Given this list of marker genes Sde2, Lsm6, Rbm48, Skic3, Ctnnbl1, Angel2, Papolb, Ttf2, Prmt9, Rbm15, Sart1, Tsen54, Prmt5, Gemin6-ps, Rbm42, Taf7, Snrpc, Ncbp3, Prpf40a, Cnot3, Gtpbp2, Cpsf2, Tut4 (NCBI Gene Id 320841), Mex3d, Zrsr2, Hnrnpk, Nudt16 (NCBI Gene Id 75686), Dhx15, Mettl14, Cwc22rt3, Cdc5lrt7, Prkrip1, Apobec1, Lsm1, Snrpb2, Cwc22rt6 (NCBI Gene Id 668119), Alyref, Dnajc17 (NCBI Gene Id 97566), Magoh, Ecd, Zmat5, Arb2a, Zbtb7a, Tent5c, App, Gemin5, Tsen2 (NCBI Gene Id 381802), Gm7324 (NCBI Gene Id 652988), Ssb, Xab2, Luc7l3, Tent5a, Obi1, Scaf8, Mtrex (Mtr4 exosome RNA helicase), Hipk3 (NCBI Gene Id 15259), Rbm7, Ess2, Dnajb11, Pcid2, Pparg, Scnm1, Taf5, Ahcyl1, Mtor, Tirap, Sart3, Samd4, Dazl, Lgals3, Cnot6, Pelo, Hnrnpr, Ago2, Igf2bp1, Hnrnpa1, Rbm14, Nr1h3, Nanos1, Tfip11, Rbmy, Ddx39a (DEAD box helicase 39a), Prpf18, Cmtr2, Zfp36, Iws1 (NCBI Gene Id 73473), Senp1, Ctif, Scaf11, Snrnp40, Ddx5, Fmr1, Prpf39, Khdrbs2, Rnpc3, Safb2, Mir7578, Eif4a3l1, Ppil1, Pus7l, Cd2bp2, Larp7-ps, Cwf19l2, Zc3h3, Wdr33, Hmx2, Nova1, Pnrc2, Raly, Gas5, Rbpms2, Dhx9, Ppp1r8, Puf60, Upf1, Ern1, Fam50a, Pus7, Rbm39, Taf6, Smg5, Zpr1, Prpf6, Gemin7, Ppwd1, Trub1, Nova2, Atf2, Taf8, Rbm4, Rbmyf6, Vdr (NCBI Gene Id 22337), Lsm2, Cstf1, Snrpert, Rbm46, Gtsf1, Nbas, Tent2, Prpf4b, Pym1, Ptbp1, Trub2, Tnf (tumor necrosis factor), Snrpe, Rbmyf3 (NCBI Gene Id 100042881), Htatsf1, Cdc5lrt1, Hnrnpu, Snrnp200, Rnf113a2, Igf2bp2, Sugp2, Celf1, Hnrnpul1, Pkp1, Cpsf6, Carhsp1, Calcr, Sltm, Srsf10, Pan2, Upf3b, Thrap3, Tnrc6b, Cpeb1, Sfpq, Cir1, Trmt61a, Secisbp2, Tcerg1, Plekhn1, Hnrnpl, Ddx41, Papolg, Smg7, Apex1, Hnf4aos, Cnot6l, Apobec2, Paf1, Celf2, Nudt16l2, Rbm10, Cdc5lrt10, Dcp1b, Rbm8a, Nudt21, Ptbp3, Rbmxl1, Cnot7, Zfp36l3, Mbnl1, Tssc4, Exosc8, Thoc3, Usp25, Brdt, Armc7, Exosc2, Pnpt1, Qki, Cnot9, Rbmx2, Supv3l1, Nanos3, Sf3b3, Pnrc1, Taf9, Rxrb, Snrnp70, Ern2, Pan3, Ubl5, Snrnp27, Fip1l1, Mettl8, Eif4enif1, Nono, Prpf19, Zc3h12d, Upf3a, Pus1, Cwc22rt2, Rock2, Rpusd3, Cactin, Med1, Cpsf1, Papola, U2af1, Zbtb1, Snrnp35, Cdk12, Mettl16, Tfcp2, Cdk13, Srsf8, Wdr77, Zfp36l1, Akr1c6, Arl6ip4 (ADP-ribosylation factor-like 6 interacting protein 4), Vegfa, Dhx40, Skic2, Gpatch8, Ythdc1, Igf2bp3, Jmjd6, Mir196a-2, Il17a, Sap18, Hbs1l, Hsf1, Luc7l2, Thumpd2, Thoc1, Safb, Rrp1b, Mapkapk2, Gcfc2, Plcb1, Tut7, Rbm33, Pias4, Ivns1abp, Nbdy, Khsrp, Dis3l, U2af1l4, Snw1, Txnl4b, Exosc4, Ints15, Patl2, Ccar2, Akap17b, Ppp4r2, Creb1, Smg6, Zfp36l2, Tent4b, Nudt12, Fastkd2, Prpf3, Srsf3, Alkbh5, Fxr1, Srsf7, Dis3l2, Rnmt, Pqbp1, Wtap, Celf6, Tent5b, Smn1, Smg1, Coil, Piwil4, Dhx38, Snrnp25 (small nuclear ribonucleoprotein 25 (U11/U12)), Traf3ip2, Brf1, C1qbp (NCBI Gene Id 28127), Hnrnpm, Slu7, Dnd1, Rbfox1, Tent4a, Gemin4 (gem nuclear organelle associated protein 4), Eri1, Slfn14, Aff2, Prpf38a, Lsm14b, Dhx8, Tnrc6a, Vip, Dbr1, Trmt6 (tRNA methyltransferase 6, NCBI Gene Id 99370), Taf13, Zfp830, Zfp326, Ptcd2 (NCBI Gene Id 68927), Aqr, Elavl1, Akap8l, Pcbp4 (NCBI Gene Id 80436), Ppil2, Rbmyf9, Srebf1 (sterol regulatory element binding transcription factor 1), Habp4, Smg9, Pabpc1, Pnn, Trp53, Etf1, Srsf4, Dkc1, Adarb1, Pabpc1l, Rbm17, Esrp1, Adar, Gdnf, Mir144, Cebpg, Syncrip, Cdc5lrt6, Lsm8, Axin2, Fastkd5, Prmt7, Pde12, Tut1, Vim, Nrde2, Rprd2, Ssu72, Lsm3, Traf5, Zcchc8, Pabpn1, Rbm25, Zcchc7, Ybx1, Sf3b1, Atxn2l, Nicol1, Ncbp1, Sf3a1, Celf5, Dhx34, Pus3, Mirlet7b, Ncoa1, Mir196b, Snrpd1, Piwil1, Cwc22rt1, Ddx17, Rara, Srek1, Rbfox2, Mir451a, Clp1, Gspt1, Parn, Dus3l, Dyrk1a, Mov10, Xrn1, Rbmyf1, Cenatac, Fam76b, Ddx42, Arglu1, Cwc22rt7, Sf3b2, Rpusd2, Crnkl1, Smndc1 (survival motor neuron domain containing 1), Nol3, Cwc25, Xrn2, Ago3, Skic8, Elavl4, Tent5d, Hnrnpf, Zranb2, Rc3h1, Khdc4 (NCBI Gene Id 99643), Sympk, Rnf113a1, Aicda, Eif3e, Ythdf3, Scgb1a1, Smg8, Zcrb1, Ybx2, Fxr2, Cnot10, Csdc2, Hltf, Pkp3, Eif4a3l2, Nudt16l1, Ikbke, Zar1, Adam3, Rbmxl2, Cwc22, Rbfox3, Polr2g, Rbm44, Clns1a, Dis3, Srpk3, Cacng7, Zc3h13, Hnrnpul2, Rprd1b, Gigyf2, Mbnl2, Edc4, Phrf1, Snrpd3, Snrpg, Larp1, Zfp473 (zinc finger protein 473), Tnrc6c, Cwf19l1 (CWF19 like cell cycle control factor 1), Snrnp48, Cdc40, Eif1, Ubl5b, Tra2a (transformer 2 alpha), Mettl3 (NCBI Gene Id 80554), S100a10, Csde1, Pcbp1, Hnrnpll, Cbll1, Bud31, Cirbp, Rbm15b, Fto, Acin1, Zhx2, Ddx39b, Hnrnpdl (heterogeneous nuclear ribonucleoprotein D-like), Patl1, Tia1, Irf3, Tsen34, Aar2, Rngtt, Abcc2, Prpf31, Rock1, Snrpf, Hspa8, Anxa2, Rbm22, Rbm38, Exosc7, Sugp1, Ythdf2, Taf10, Sf3b5, Hnrnpc, Piwil2, Slirp, Nup98, Rbm4b, Rbm6, Arvcf, Cnot1, Traf2, Rbm20, Syf2, Eif4a3, Pnldc1, Khdrbs1, Zc3h14, Cdk9, Rbbp6, Snip1, Lsm7, Tbp, Nfkbiz, Nsrp1, Caprin1, Dhx16, Gtpbp1, Rnasel, Apobec4, Casc3, Ncbp2, Lncbate1, Ncl, Fastk, Srsf6, Ccnb1, Foxe3, Ppih, Ythdf1, Rbm24, Paip1, Fastkd3, U2af2, Usp49, Aplp1, Wbp4, Ppie, Celf3, Rnps1, Rbm28, Slbp (NCBI Gene Id 20492), Ago1, Bcas2, Rpusd4, Ddx20, Myd88, Noct, Tdrd6, Taf3, Rbm3, Son, Ptbp2, Nanos2, Cript, Khdrbs3, Prpf8, Gpkow, Trmt2a, Cpeb3, Cpsf7, Taf2, Fra10ac1, Ddx23, Mir451b, C5ar1, Wdr83, Pum2, Pcf11, Cdc5l, Srsf1, Mfap1b, Cmtr1, Cstf2t, Upf2, Scaf1, Exosc10, Exosc5, Cdc5lrt8, Thoc6, Grsf1, BC005624, Ncoa2, Srrm2, Srek1ip1, Gemin2, Ap3b1, Sf3b4, Wbp11, Rbm8a2, Supt6, Epas1, Adarb2, Srrm4, Mir466l, Strap, Nr1h2, Cnot8, Sp1, Scaf4, Kat8, Pum1, Srpk1, Prkaca, Taf15, Prdx6, Mblac1, Thoc5, Mtpap, Larp4b, Bud13, Zc3hav1, Thrb, Esrp2, Pabpc2, Tra2b, Paxbp1, Zic3, Hdac7 (NCBI Gene Id 56233), Snrpa, Yju2b, Srsf9, Taf4, Nsun2, Mir196a-1, Exosc9, Npm1, Gemin8, Zmat2, Rbm47, Tsen15, Meioc, Lsm5, Cwc22rt4, Ppil3, Hnrnpa3, Rbm11, Txnl4a, Ilf3, Gemin6, Isy1, Prpf40b, Hspa1a, Enpp1, Snrpa1, Rbpms, Cwc15, Prdx6b (NCBI Gene Id 320769), Virma, Fbxo24, Snrpb, Trmt10c (NCBI Gene Id 74765), Sf1, Mirlet7c-1, Srrm1, Tesk1, Hnrnpa2b1, Hspa1b, Gpatch1, Usp4, Hnrnpa0, Btg2, Rxra, Thoc2 (THO complex 2), Srpk2, Yju2, Lsm4, Pcif1, Ddx47, Sf3a3, Dicer1, Cdc73, Fus, Taf12, Taf11, Ttc5, Clasrp, Boll, Samd4b, Atm, Ddx1, Prr5l, Phf5a, Dcp2, Plrg1, Slc39a5, Exosc3, Cdc5lrt9, Myod1, Tardbp, Malat1, Eftud2, Snrpd2, Snd1, Ago4, Myg1, Chd8, Arid5a, Dhx36, Zfp64, Thoc7, Slc11a1, Snrpn, Hnrnpab, Lmntd2, Bag4, Alyref2, Stat3, Smu1, Cstf3, Ik, Luc7l, Tob1, Tbrg4, Fastkd1, Rida, Cpsf4, Hnrnpd, Cstf2, Sfswap, Taf1, Celf4, Dxo, Srsf12, Prpf38b (PRP38 pre-mRNA processing factor 38 (yeast) domain containing B), Snu13, Rest, Taf4b, Magohb, Rsrp1, Cwc22rt5, Lsm11, Rbm41, Thra, Larp7, Frg1, Dcps, Cnot2, Atf4, Rbmx, Sf3a2, Rbm5, Rsrc1, Mfap1a, Dazap1, Sf3b6, Lsm10, Setx, E2f1, A1cf, Mirlet7c-2, Kin, Cdc5lrt5, Ereg, Ramac, Flna, Mlh1, Gspt2, Psip1, Ddx46, Mrto4, Rc3h2, Mbnl3, Exosc6, Prpf4, Sap18b, Usp39, Edc3, Rprd1a, Leo1, Dcp1a, Trim71, Cpsf3, Srsf5, Pabpn1l, Hnrnph1, Cdc5lrt4 (NCBI Gene Id 668191), Srsf2, Pabpc4, Zc3h12a, Srrt, here is a description of the gene set: Mouse Gene Set: GOBP_MRNA_METABOLIC_PROCESS The chemical reactions and pathways involving mRNA, messenger RNA, which is responsible for carrying the coded genetic 'message', transcribed from DNA, to sites of protein assembly at the ribosomes. studied in species Mus musculus